The following is a description of a gene set: species: Homo sapiens Activation of NOXA and translocation to mitochondria Human Gene Set: REACTOME_ACTIVATION_OF_NOXA_AND_TRANSLOCATION_TO_MITOCHONDRIA, and this is the list of marker genes: TFDP2, TFDP1, E2F1, TP53, PMAIP1